The following is a description of a gene set: Mid Schwann from publication He P, Lim K, Sun D, Pett JP, Jeng Q, Polanski K, Dong Z, Bolt L, Richardson L, Mamanova L, Dabrowska M, Wilbrey-Clark A, Madissoon E, Tuong ZK, Dann E, Suo C, Goh I, Yoshida M, Nikolić MZ, Janes SM, He X, Barker RA, Teichmann SA, Marioni JC, Meyer KB, Rawlins EL (PMID 36493756) species: Homo sapiens Human Gene Set: HE_LIM_SUN_FETAL_LUNG_C7_MID_SCHWANN_CELL, and this is the list of marker genes: LAMP5, BHLHE40, ABCA8, ALOX15, COL5A1 (collagen type V alpha 1 chain), MAF (MAF bZIP transcription factor), EGR3, ANK3, SPHK1, PTPRE, PLP2, RASL12, SH3PXD2B, L1TD1, SPP1, SCN7A, CCL2, S1PR3, MYO1C, RGS10, ADAMTS5, NR2F1-AS1, VGLL3, VWA1, CTXND1, ENTPD2, ATP1A2, AHNAK (AHNAK nucleoprotein), FBLN2, COL19A1, APOA1, LAMB2, UGT8 (NCBI Gene Id 7368), SLITRK5, PON2, XKR4, COL4A1, NR2F2-AS1, HBA1, TNS1, PLEC, EGFL8, ANGPTL4, EEIG1, SRGAP2B, GLRB, IFITM2, FRMD4B, CXCL16, TAFA5, CD82, COL14A1, SEMA3B, SYNGR2, SH3BP5, IGSF11, ANGPTL7, LRRTM1, COL28A1, TMPRSS5, ZCCHC24, DHRS3, SORBS2, WWP1, RAB20, KIRREL2, LRIG1, SEMA3G, COBL, ENPP2, ITGA2, ALCAM, COL16A1, TMEM176A, JAG1, MBP, FNDC3B, COL3A1, MAOB, LTBP3, GJC3, CAHM, CRYL1, KANK4, HSPG2, GASK1B, PDGFC (platelet derived growth factor C), NTRK3, LATS2, GPR155, OLFML2A, NIBAN1, LGALS3, HSPA12A, ST6GALNAC2, VLDLR, AATK, TMC6, AXL, P4HA2, CD59, STARD9, MYL9, DAG1 (dystroglycan 1), ARHGEF26, ARHGAP15, PRRT1, IFIT2, PHLDA3, TNFRSF12A, KCTD11, GFRA3, TMEM35B, LIPT1, PLEKHG3, HPDL, PLXDC2, FBLN5, SRGAP2C, DEPTOR, CAVIN3, GAS2L3, ITGB4, CDK18, FGL2, SAMHD1, MAL, SLITRK2, TENT5A, ERBB2, LINC02256, FSTL5, EMP3, TNC, MT1X, GNG12, PLLP, SLIT2 (slit guidance ligand 2), PRSS23, ANKRD28, TINAGL1, ENDOD1, ITGB8 (NCBI Gene Id 3696), HBEGF (NCBI Gene Id 1839), NTRK2, RDH10, SPMIP5, LOXL2, NID2, GAL3ST1, NRBP2, IL34 (interleukin 34), ITIH5, IFI6, LPL, ESPN, TGFBR3, SEMA7A, IQGAP2, MAG, TCIM, HBA2, LRRC4, WIPI1, CLMN, PPT2-EGFL8, NEK6, TSPAN11, PRKCD, AQP1, LPCAT2, SPON2, TLL2, PLSCR4, DHH (NCBI Gene Id 791256), TRPM3, ITPR3, PPARA, SELENOM, PDIA5, LRP10, TNFAIP6, RELN, TTYH2, FN1, COL27A1, ANXA1, ATG16L2, PLEKHA4, SBSPON, THBS1, PLXNB3, COL5A3, LPAR1, RHBDF1, RHOJ, EPHA5, KLK6, LAMB1, MIA, TFPI2, MATN2, LETR1, TNS3, ASPA, SH3D19 (NCBI Gene Id 152503), SSPN, CASKIN2 (NCBI Gene Id 57513), CAVIN1, PMP2 (NCBI Gene Id 5375), ANXA3, TPBG, ITM2A, FSTL3, SH3GL3, LIPA (NCBI Gene Id 3988), RXRG, NXPE3, COL15A1, BCAN, SMTN, ZBTB7A, OLFML2B, CLSTN2, PRIMA1, CLDN19, GPR137B, GATM (glycine amidinotransferase), GNG11, PDK4, BMP1, SORBS1, SLC1A4, CDH1 (NCBI Gene Id 999), LIMCH1 (LIM and calponin homology domains 1), ADAMTS9 (NCBI Gene Id 56999), PDPN (NCBI Gene Id 29912), NR2F1, NRXN3, IFIT3, ART3, HEY1, BACE2, TMEM176B, PLAAT3, PCDH7, RGCC, ELOVL1, ADAM9, LAMA2, UTRN, RASSF4, COL4A5 (collagen type IV alpha 5 chain), TSPAN15, RAB31, SIPA1L2, DCN, FAM114A1, HLA-B (NCBI Gene Id 730410), CDC42EP5, SOSTDC1 (sclerostin domain containing 1), NFKB2, SMIM5, RPS4Y1 (ribosomal protein S4 Y-linked 1), PPP1R1C, MICALL2, FCGRT, KDELR3